Given this list of marker genes Myh10, Prmt8, Rhoa, Marcks, Itsn1, Amot, Tiam1, Cttnbp2, Kalrn, Ptk2, Cyfip1, Dip2a, Cap2, Baiap2, here is a description of the gene set: Mouse Gene Set: GOBP_REGULATION_OF_MODIFICATION_OF_POSTSYNAPTIC_ACTIN_CYTOSKELETON studied in species Mus musculus Any process that modulates the frequency, rate or extent of modification of postsynaptic actin cytoskeleton.